The following is a description of a gene set: from publication Scherer CA, Magness CL, Steiger KV, Poitinger ND, Caputo CM, Miner DG, Winokur PL, Klinzman D, McKee J, Pilar C, Ward PA, Gillham MH, Haulman NJ, Stapleton JT, Iadonato SP (PMID 17651872) species: Homo sapiens Gene expression in human peripheral blood mononuclear cells was systematically evaluated following smallpox and yellow fever vaccination, and naturally occurring upper respiratory infection (URI). All three infections were characterized by the induction of many interferon stimulated genes, as well as enhanced expression of genes involved in proteolysis and antigen presentation. Vaccinia infection was also characterized by a distinct expression signature composed of up-regulation of monocyte response genes, with repression of genes expressed by B and T-cells. In contrast, the yellow fever host response was characterized by a suppression of ribosomal and translation factors, distinguishing this infection from vaccinia and URI. No significant URI-specific signature was observed, perhaps reflecting greater heterogeneity in the study population and etiological agents. Taken together, these data suggest that specific host gene expression signatures may be identified that distinguish one or a small number of virus agents. Human Gene Set: SCHERER_PBMC_YF_VAX_AGE_18_40YO_ANYD_DN Genes down-regulated in peripheral blood mononuclear cell in adults (18-40) after exposure to YF-Vax, time point anyD, and this is the list of marker genes: SLC25A6, RPS7, EGLN2, RPS13, LIF, NDUFV1, RPS2, TMEM259, DPP7, VAV1, PRB3, EIF4B (eukaryotic translation initiation factor 4B), COL6A2, APRT, CORO1A, CCNI, BRAT1, ATP5MJ (NCBI Gene Id 9556), FBXW5